Given this list of marker genes Ap2m1 (NCBI Gene Id 11773), Commd1, Apoc3, Apob, Clu, Lrpap1, Picalm, Apoe, Lrp2, Ldlrap1, Cltc, Ankra2, App, Sacs, Dnaja1, Apoa5, Apoa2, Crp, Snx17 (sorting nexin 17), Dkk1, Ap2a1, Mesd, Apbb3, Nherf2, Lancl1, Dab2, Mmp13, Apoa1, Pcsk9, Washc1 (NCBI Gene Id 68767), Hsp90b1, Reln, Syt1, here is a description of the gene set: species: Mus musculus Mouse Gene Set: GOMF_LIPOPROTEIN_PARTICLE_RECEPTOR_BINDING Binding to a lipoprotein particle receptor.